The following is a description of a gene set: A protein complex that consists of a homo- or heterodimer of members of a family of structurally related proteins that contain a conserved N-terminal region called the Rel homology domain (RHD). In the nucleus, NF-kappaB complexes act as transcription factors. In unstimulated cells, NF-kappaB dimers are sequestered in the cytoplasm by IkappaB monomers; signals that induce NF-kappaB activity cause degradation of IkappaB, allowing NF-kappaB dimers to translocate to the nucleus and induce gene expression. studied in species Homo sapiens Human Gene Set: GOCC_NF_KAPPAB_COMPLEX, and this is the list of marker genes: RELB, RPS3, NFKB1, RELA, REL